The following is a description of a gene set: Genes up-regulated in comparison of dendritic cells (DC) stimulated with LPS (TLR4 agonist) at 8 h versus DC cells stimulated with Pam3Csk4 (TLR1/2 agonist) at 8 h. mouse primary BMDCs were stimulated with tlr ligands and gene expression changes were profiled on Affymetrix arrays studied in species Homo sapiens from publication Amit I, Garber M, Chevrier N, Leite AP, Donner Y, Eisenhaure T, Guttman M, Grenier JK, Li W, Zuk O, Schubert LA, Birditt B, Shay T, Goren A, Zhang X, Smith Z, Deering R, McDonald RC, Cabili M, Bernstein BE, Rinn JL, Meissner A, Root DE, Hacohen N, Regev A (PMID 19729616) Human Gene Set: GSE17721_LPS_VS_PAM3CSK4_8H_BMDC_UP, and this is the list of marker genes: CCNB1IP1, TNFRSF25, PCCA, RGS2, KCTD10, PLEKHG6, HTRA2, TRIP12, CPA3, RCSD1, CHRNA3, DBNL (NCBI Gene Id 28988), CMTR1, IL10RA, AP3M2, RNF114, ETV6, PCDH15, RAB8B, DNAJC14, RESP18, SMC5 (structural maintenance of chromosomes 5), RFFL, SLC44A2, TYK2, NDUFS4, MACROH2A1, HMGN3, SWAP70, BLNK, CDKN1B, NQO2, ANKS1A, PCSK7, ST3GAL1, CSRP1, SH3GLB1, SLF1, FCGRT, RAB13, AP1G2, ALDH1A2, ZNF654, NIT2 (NCBI Gene Id 56954), MXD1, IGFBP4, TXNDC17, MOB1B, WASHC1, MAP3K8, RAD21, STXBP3, NSMAF, HLA-B, LIMA1, TSPO, PTCH1, KLF6, KIAA0319L, TNFSF8, ASAH2, TSC22D4, GNG2, MARVELD3, UBE2D1, ATF3, ASF1A, SORCS2, HOXC4, USF1 (upstream transcription factor 1), ZFP36, TRA2A, PDLIM4, TNFSF10, KLRK1, NTS, PDE1B (NCBI Gene Id 5153), RNF115, VAMP3, RNF19B, PFKP, TRAPPC14, ARHGAP12 (NCBI Gene Id 94134), ANXA11, CELA1, ATOSB, PLOD3, DUSP2 (dual specificity phosphatase 2), SLBP, PPDPF, HSPA1A, FAM110A, CALB1, ATXN7L3, CD164, TTC36, RAP2C, ZFAND3, PLEKHO1, UBE2B, NAA20, TNC, CDK14, CCNE1, SFXN2, CRKL, CEP19, FBXO25, NPTX2, NDUFS3 (NADH:ubiquinone oxidoreductase core subunit S3), RIPK1, DUSP1, C8orf33, ENOX2, LGALS3BP, TNXB, DNAJC2, TJP1, GATAD2A, KMT5B, HMGN5, IQGAP2, SUV39H1, PLEKHS1, HINFP, SCIN, SNX10, NDRG1, RUNX2, GLA, NRDE2, PSMB8, SAT1, CREB1, STAT4 (signal transducer and activator of transcription 4), PMPCB, GTPBP2, DNMT3A, MOCOS, TNFRSF11A, CASP1, FBXW9, TRIM6, RAB25, SDCBP2, PLAT, PNPT1, PSMA4, MAFK, IFT172, FXR1, GPHN, CSF1, AKT2, SPTLC2, TXNDC16, GRN, P2RY12, ARF3, MINPP1, GBP4, TLE4 (NCBI Gene Id 7091), MESP2, ASPA, CAPN2, EPGN, ENPP4, KYAT3, MTHFS, ASGR2, PDCD10, GASK1B, GTF2F1, ECE2, MCL1, CNBD2, NRBF2, SNRNP27, ITIH1, SLC40A1, TLR7, DPCD, HIVEP1, STX2, ECE1, BAK1 (BCL2 antagonist/killer 1), PDE7B, SPTSSB, MFSD6 (NCBI Gene Id 54842), DOP1B, KMT2A, ARHGAP17, LTA, GLIPR2 (NCBI Gene Id 64148), GABRA6, RBM17 (NCBI Gene Id 84991), CCR1, RGS14, SERTAD3, BATF2